Given this list of marker genes Slc7a1, Slc15a4, Slc38a5, Slc66a1, Slc38a3, here is a description of the gene set: Mouse Gene Set: GOMF_L_HISTIDINE_TRANSMEMBRANE_TRANSPORTER_ACTIVITY species: Mus musculus Enables the transfer of L-histidine from one side of a membrane to the other. L-histidine is 2-amino-3-(1H-imidazol-4-yl)propanoic acid.